The following is a description of a gene set: The directed movement of the Golgi to a specific location. studied in species Homo sapiens Human Gene Set: GOBP_ESTABLISHMENT_OF_GOLGI_LOCALIZATION, and this is the list of marker genes: RIPOR1, CDC42, PDCD10, YWHAZ, COPG1, STK25, NHERF1, ARHGAP21